The following is a description of a gene set: Mouse Gene Set: GOBP_NEGATIVE_REGULATION_OF_RYANODINE_SENSITIVE_CALCIUM_RELEASE_CHANNEL_ACTIVITY Any process that decreases the activity of a ryanodine-sensitive calcium-release channel. The ryanodine-sensitive calcium-release channel catalyzes the transmembrane transfer of a calcium ion by a channel that opens when a ryanodine class ligand has been bound by the channel complex or one of its constituent parts. species: Mus musculus, and this is the list of marker genes: Casq2, Gsto1, Calm2, Pkd2, Sri, Calm1, Gstm7